The following is a description of a gene set: Mouse Gene Set: GOBP_REGULATION_OF_CALCIUM_ION_BINDING Any process that modulates the frequency, rate or extent of calcium ion binding. studied in species Mus musculus, and this is the list of marker genes: Mrln, 1810037I17Rik, Sln, Pln, Smim6